Given this list of marker genes APOM, SLCO1A2, ASGR1, CFHR1, ENHO, TFR2, CPN2, C8G, INSC, KCNN2, AGMAT, TKFC (triokinase and FMN cyclase), TTC39C, F13B, FAAH, HSD3B7, SAA4, IL1RAP, HEBP1, SLC22A7, RDH16, XYLB, CFI, HSD3B2, RARRES1, UGT3A2, CLDN2, TNFAIP8L1, C6, F11, FITM1, VWCE, ENPP3, RDH5, GCGR, TPMT, SDR9C7, AADAT, NLRP6, CES3, SERPINA3, MFSD4B, ETHE1, SLCO2B1, ABAT, APONP, AADAC, KMO, SULT1B1, SLC22A25, ALDH8A1, ERBB3, SARDH, HAAO, MTTP, SLC47A1, SC5D, UGT2B4 (UDP glucuronosyltransferase family 2 member B4), SERPINA12, AQP8, ALAS2, CA5A, CYP2D6, CYP2A6, PNPLA7 (NCBI Gene Id 92716), PCYT2, MPDZ, SPP2, MCM10, NAT8, PRKD3, HAO1, GJB2, KYAT1, C9, RARRES2, LIFR, GCHFR, BDH1, ARHGAP9, IYD, S100A10, APOA4, SERPINF1, OTC, CYP2F1, MBL2, APOC2 (NCBI Gene Id 344), PXDC1, NUDT7, CYP2C23P, PGLYRP2, CYP2C8, PRODH2, CES2, HAVCR1 (hepatitis A virus cellular receptor 1), SUCNR1, DDC, CES1, SPATA2L (NCBI Gene Id 124044), CYP2U1 (NCBI Gene Id 113612), CEACAM1, SHMT2, SULT2A1, SLC45A3, UGT2A3, PROZ, ACP5, ADH4, CYP4V2, LIPC, TFPI2, DEGS1, ACSM1, ELOVL3, SRD5A1 (steroid 5 alpha-reductase 1), GLYAT, SLC27A5, WFDC21P, PDZK1, EGFR, ABCC6, QPRT, SLC17A3, FAM107B, SERPINA1, HYKK, CIDEB, HRG, NR1I3, BAAT, CMAHP, DIO1, C4BPA, PERP (NCBI Gene Id 64065), SLC30A10, ENTPD8, HSD17B2, MASP1, PLA2G12B, BBOX1, ZFAND4, MFSD2A, B3GALT1, ADRA1B, ASPDH, THEM7P, PZP, HSD3B1, NOX4, FABP2, SHLD2, SOAT2, AQP11, F12, TLCD2, MBL1P, CLDN1, TMEM30B, CYP8B1, C8A, CCL15, SLC3A1, TMC7, CYP7B1, SLC23A1, C8B, CTSH, NLRP12, SMLR1, here is a description of the gene set: Type 1 iodothyronine deiodinase (Dio1), a selenoenzyme catalyzing the bioactivation of thyroid hormone, is highly expressed in the liver. Dio1 mRNA and enzyme activity levels are markedly reduced in the livers of hepatocyte nuclear factor 4alpha (HNF4alpha)-null mice, thus accounting for its liver-specific expression. Consistent with this deficiency, serum T4 and rT3 concentrations are elevated in these mice compared with those in HNF4alpha-floxed control littermates; however, serum T3 levels are unchanged. Promoter analysis of the mouse Dio1 gene demonstrated that HNF4alpha plays a key role in the transactivation of the mouse Dio1 gene. Deletion and substitution mutation analyses demonstrated that a proximal HNF4alpha site (direct repeat 1; HNF4alpha-RE) is crucial for transactivation of the mouse Dio1 gene by HNF4alpha. Mouse Dio1 is also stimulated by thyroid hormone signaling, but a direct role for thyroid hormone receptor action has not been reported. We also showed that thyroid hormone-inducible Krüppel-like factor 9 (KLF9) stimulates the mouse Dio1 promoter very efficiently through two CACCC sequences that are located on either side of HNF4alpha-RE. Furthermore, KLF9 functions together with HNF4alpha and GATA4 to synergistically activate the mouse Dio1 promoter, suggesting that Dio1 is regulated by thyroid hormone in the mouse through an indirect mechanism requiring prior KLF9 induction. In addition, we showed that physical interactions between the C-terminal zinc finger domain (Cf) of GATA4 and activation function 2 of HNF4alpha and between the basic domain adjacent to Cf of GATA4 and a C-terminal domain of KLF9 are both required for this synergistic response. Taken together, these results suggest that HNF4alpha regulates thyroid hormone homeostasis through transcriptional regulation of the mouse Dio1 gene with GATA4 and KLF9. Genes down-regulated in liver samples of liver-specific knockout of HNF4A. from publication Ohguchi H, Tanaka T, Uchida A, Magoori K, Kudo H, Kim I, Daigo K, Sakakibara I, Okamura M, Harigae H, Sasaki T, Osborne TF, Gonzalez FJ, Hamakubo T, Kodama T, Sakai J (PMID 18426912) Human Gene Set: OHGUCHI_LIVER_HNF4A_TARGETS_DN studied in species Mus musculus